Given this list of marker genes Abca2, Pdgfa, Apoc1, Lpcat1, Slc27a1, Pdgfb, here is a description of the gene set: studied in species Mus musculus Mouse Gene Set: GOBP_NEGATIVE_REGULATION_OF_PHOSPHOLIPID_METABOLIC_PROCESS Any process that stops, prevents or reduces the frequency, rate or extent of phospholipid metabolic process.